The following is a description of a gene set: part of: p75 NTR receptor-mediated signalling species: Mus musculus Reactome Pathway: NFG and proNGF binds to p75NTR electronically inferred by orthology from the curated human pathway This event has been computationally inferred from an event that has been demonstrated in another species.<p>The inference is based on the homology mapping from PANTHER. Briefly, reactions for which all involved PhysicalEntities (in input, output and catalyst) have a mapped orthologue/paralogue (for complexes at least 75% of components must have a mapping) are inferred to the other species., and this is the list of marker genes: Ngfr (nerve growth factor receptor (TNFR superfamily, member 16)), Ngf